The following is a description of a gene set: species: Mus musculus Mouse Gene Set: GOBP_MEIOTIC_CELL_CYCLE Progression through the phases of the meiotic cell cycle, in which canonically a cell replicates to produce four offspring with half the chromosomal content of the progenitor cell via two nuclear divisions., and this is the list of marker genes: M1ap, Eme1 (essential meiotic structure-specific endonuclease 1), Majin, Rbm7, Spdya (speedy/RINGO cell cycle regulator family, member A), Grb14, Rpa1, Gm4297, Rsph1, Ncaph, Shcbp1l, Syce1l, 4930447C04Rik, Brme1, Gm29276, Mre11a, Fkbp6, Psmc3ip, Fhad1, Meiob, Ubb, Washc1, Washc5, Cdk2, Gm29554, Sycp3, Boll, Osm, Gm21865, Rad1, Ppp2ca, Ska2 (spindle and kinetochore associated complex subunit 2), Tex14, Smc2, Pld6, Usp17le, Hormad1, Xlr4a, Ndc1, Gm14525, Cyp26b1 (cytochrome P450, family 26, subfamily b, polypeptide 1), Btbd18, Nsun2, Stk35, Pms2, Ovol1, Spire2, Slx4 (SLX4 structure-specific endonuclease subunit homolog (S. cerevisiae)), Gm20736, Ednra (endothelin receptor type A, NCBI Gene Id 14737), Smc1b, Ddb1, Sirt7, Prdm9, Top2b, Siah1a, Gm20911, Ncapd3, Slc26a8, Plk1, Psmd13, Mei4, Haspin, Ndc80, Tubgcp2, Foxj3, Gm28919, Incenp, Npm2, Ccnb1ip1 (cyclin B1 interacting protein 1), Slc25a31, Rnf212b, Bub3, Gpr3, Slxl1, Ehmt2, Actr2, Tdrkh, Syce3, Pttg1, Top2a, Tex15, Dicer1, Mcmdc2, Topbp1, Zcwpw1, Rad51c, Ago4 (argonaute RISC catalytic subunit 4), Gm21294, Iho1, Tdrd9, Smc3 (NCBI Gene Id 13006), Nanos2, Exd1 (NCBI Gene Id 241624), Stag3, Gm28576 (NCBI Gene Id 101056210), Mus81, Mybl1, Cenpx, Chtf18, Hus1b, Nr2c2, Catsperz, H1f8, Smc4, 3830403N18Rik, 1700028K03Rik (RIKEN cDNA 1700028K03 gene), Gm28102, Zwint, Spo11, Igf1r, Gm21095, Fmn2, Gm21117, Hsf1 (heat shock factor 1), Syde1, Mcm2, Rbm46, Xlr3b, Prkaca, Gm28870 (predicted gene 28870), Gm2012, Piwil2, Gm1993, Gm7958, Actr3, Xlr, Tex12, Gm10488, Rad50, Tubg2, Ereg, Spata22, Rmi1, Birc5, Xlr4c, Insr, Hsf2bp, Rad51ap1, Cenpc1, Wnt5a, H2ax (H2A.X variant histone), Prkacb, Ska1, Syce2, Orc4, Nek2, Slx, Stra8, Wee2, Rad21l, Tubgcp5, Dusp1, Kctd19, Tesmin (NCBI Gene Id 17771), Tubgcp3, Xrn1, Ing2, Marf1, Gm20817, Gm6121, Gm20870 (NCBI Gene Id 73329), Ubr2, Ttk, Cpeb1, Sun2, Fanca, Rec8, Eme2, Npr2, Mlh3, Kash5, Lfng (LFNG O-fucosylpeptide 3-beta-N-acetylglucosaminyltransferase), Brca2, Xlr5a, Gm5168, Tubgcp4, Pkmyt1, Meioc, Dnmt3l, Atm (ataxia telangiectasia mutated), Rnf212, Mettl3, Msh4, Ercc4, Hfm1, Clgn, Aspm, Fancd2, Tex19.1, Cenps (centromere protein S), Fancm, Psma8, Cdc25c, Spin1 (spindlin 1), Pnma5, Edn1, Mnd1, Ska3, Spire1, Suv39h2, Mcm6 (minichromosome maintenance complex component 6), Morc2b, Lif, Kif18a, Sun1, Dmc1, Bcl2l11, Gm1140, Mapk15, Rspo1, Dazl, Gm2030, Rpl10l, Msh5, 1700013H16Rik, Utp14b, Cks2, Gja1, Gm21996, Gm20820, Msx1, Chfr, Hsf5, Ankrd31 (ankyrin repeat domain 31), Xlr3a, Aurka, Shoc1, Meiosin, Syce1, Fignl1, Gm21627, Brdt, Rbbp8, Rad51d, Mki67, Rad54b, Exo1, Zfp541, Calr, Myh9, Ccnb2, Gm773, Ooep, Hormad2, Tdrd12, Meikin, Camk2b, Mos, Ccnb3, Gm5935, Ccna1, Gm21760, Ankle1, Zfy2, Mlh1, Ythdc2, Mastl, Tex19.2, Eif4g3, Redic1, Cenpe, Nuf2, Gm21858, Pde3a, Trim75, Mns1, Meig1, Tdrd1, Ythdf2, Zfp318, Ddx4, Ube2b, Zscan21, Arhgap33os, Hspa2, Cntd1, Xlr4b, Pdik1l, Prr19, Rad51, Top6bl, Ncapd2 (NCBI Gene Id 72814), Foxj2, Cdc20, Clasp2, Terb1, Fzr1, Piwil1, Mcm4, Bag6, Pten, Mcm3, Terf1, Hus1, Gm28961 (predicted gene 28961), Mcm5, Mapk1ip1, Gm20843, BC005624, Sycp2, Xlr5b, Fbxo5, Terb2, Gm20824, Ppp2r1a (protein phosphatase 2, regulatory subunit A, alpha), Septin1 (septin 1), Sgo2a, Nppc, Dmrtc2, Knl1, Fbxo43, Stag2, Gm5934, Atrx, Sgo1, Cdc25b (NCBI Gene Id 99033), Plcb1, Wnt4, Sycp1, Ccne1, Espl1, Ncaph2, Gm28510, Rps6ka2, Dcaf13, Mcm7, Sirt2, Cdc25a, Mov10l1, Rec114, Golga2, Lsm14b, Gm5169, Brip1, Aurkc, Asz1, Gm29866, Gm20890, Rad54l, Ccne2, Cep63, Nbn, Mei1, Tubg1, Bend2, Tubgcp6, Numa1, Xlr5c, Smc1a, Xlr3c, Hmga2, Piwil4, Gsk3b, Tex11, Trip13, Dmrt1, Mael, Gm10230, Msx2, Klhdc3